The following is a description of a gene set: Any process that enhances the establishment or increases the extent of the excitatory postsynaptic potential (EPSP) which is a temporary increase in postsynaptic potential due to the flow of positively charged ions into the postsynaptic cell. The flow of ions that causes an EPSP is an excitatory postsynaptic current (EPSC) and makes it easier for the neuron to fire an action potential. Mouse Gene Set: GOBP_POSITIVE_REGULATION_OF_EXCITATORY_POSTSYNAPTIC_POTENTIAL species: Mus musculus, and this is the list of marker genes: Igsf11, Grin2d, Prkar1b, Reln, Grin2a, Neto1, Grin2b, Gsk3b, Stx1a, Nlgn2, App, Dbn1, Dvl1, Ssh1, Cux2, Baiap2, Ngfr, Stx1b, Gria1, Cacnb3, Nlgn3, Rims1, Shank3, Grin2c, Pten, Prkcz, Drd4, Grin1, Shank1, Dlg4, Rgs4, Nrxn1, Chrna7 (NCBI Gene Id 11441), Wnt7a, Nlgn1, Rims2, Grip2, Tbc1d24, Adrb2, Neto2, Ptk2b, Afdn, Grk2